Given this list of marker genes ACP5, ARL3, IKBKG, MBTPS2, SMAD4, FGFR2, DHCR7, TBXAS1, NEPRO, OCRL, PLOD2, ACVR1, PMM2, NOTCH3, VPS35L, TBX15 (NCBI Gene Id 6913), B3GLCT, EIF5A, RPL13, PPP1R15B, JAG1, LRP4, PLOD1, CLCN7, ELN, CDH11, UFSP2, FBN1, PPIB, PUF60, CEP104, ADAMTSL2, DVL1, WBP11, CRTAP, LAMA5, KIF22, BGN, RNU4ATAC, GORAB, LTBP3, DPP9, RAD21, AKT1, FANCC, GUSB, SLC39A13, ARSK, IPO8, CFAP410, LIMK1, VANGL2, TMEM218, RAB33B, ALG12, DLL3, ERI1, PTH1R, COL1A1, FANCB, HYLS1, SRP54, CTBP1, ANTXR1, IFT43, TMEM237, UBE3B, ARSB, SOST, COL9A3, HES7, FZD2, ROR2, PYCR1, THPO, TBXT (NCBI Gene Id 6862), RTL1, SH3PXD2B, XYLT1, TENT5A, WASHC5, PDE4D, SERPINF1, CCL2, COL2A1, LYSET, DDR2, KDM6A, FKBP6, RMRP, SUMF1, SKI, DNA2, WNT5A, NSD2, ALPL, ARL13B, P3H1, AEBP1, B3GALT6, KATNIP, MRPS28, TAPT1, RIPPLY2, GTF2I, MMP2, VPS37D, TONSL, KIAA0753, PCYT1A, DNAJC30, METTL27, ZFX, NEU1 (neuraminidase 1), SON, STX1A, ADA (adenosine deaminase), CSF1R, LIFR, HHAT, SOX5, GLB1, DLK1 (NCBI Gene Id 8788), MEG3, MIA3, MBD5, SFRP4, GPX4, GJA1, PIGG, PHLDB1, FOXF1, BUD23, H3-3B, IHH, NOTCH2, FLI1, TBX2, CHRNG, OBSL1, IARS2, DNAJC21, SEC23A, APC, DDRGK1, TRPV4, CANT1, COL9A1, OFD1, CCN2, SPARC, SF3B4, GTF2IRD2, KCNJ8, KYNU, PTCH2, TCTN1, TRIP11 (thyroid hormone receptor interactor 11), CLIP2, MKS1 (NCBI Gene Id 54903), XYLT2, OTUD5, SLC35D1, CUL7, CYP27A1, AHI1, SC5D, USP8 (ubiquitin specific peptidase 8), PEX7, P4HB, TBL2, TBX6, CAPN15, BMP4, EXOC6B, RINT1, FGFR1, CPLANE1, CEP120, GLE1, GTF2IRD1, MESP2, SGMS2, HGSNAT, IFITM5, NMNAT1, ACTB (NCBI Gene Id 60), TOMM7, AIFM1, KDELR2, FIG4, NOTCH2NLC, CHST3, SUFU, WNT1, SLC29A3, MMP13, IFT74, ORC1, COL10A1, BMP1, TCIRG1, COL9A2, EIF2AK3, CCDC8, COL1A2, ARSL, LFNG, POR, NCF1, PIBF1, CDK10, MATN3, NEK1, PLOD3, RSPRY1, POLR3A, CCDC22, PTCH1, MAN2B1, RPS6KA3, MAFB, HSPG2, ALDH1A2, FUZ, MAP3K7, CHD7, CSPP1, TOGARAM1, SEMA3E, SEC24D, SIX6, NAGLU, PIEZO2, SGSH, GNPNAT1, PRKG2, COG1, RFC2, ITCH, TCTN2, TMCO1, ANKRD11, FUCA1, MPL, AIP, SMARCAL1, LTBP1, INPPL1, SLC26A2, GNS, POP1, TWIST1, SERPINH1, TMEM67, BCL11A, TNFRSF11A, CHN1, CEP41, COMP, EIF4H, PDE6D, CBY1 (chibby 1, beta catenin antagonist), CCN6, SOX2, COL11A1, RPS19, INPP5E, SBDS, COG4, PLEKHM1, EXTL3, LRRK1, TBC1D24, TCTN3, IDH1, BAZ1B, VANGL1, DPYSL5, VDR, EBP, NPR2, GNPTAB, FGFRL1, B9D1, MMP14, NELFA, PRKAR1A (NCBI Gene Id 5573), FN1, PAM16, FLNA, NKX3-2, DYM, DVL3, NF1, SALL4, CBS, KMT2D, GALNS, LONP1, AGA, LETM1, ENPP1 (NCBI Gene Id 5167), PTDSS1, PLCB3, GNPAT, FLNB, CSGALNACT1, SF3B2, CPLX1, GLI3, CREB3L1, FGFR3, SMOC1, B9D2, MAX, NANS, LRP5, AXIN1, SLC25A24, ABCC9, HAAO, STAG2, HSPA9, HDAC6, LBR, WNT7A, PAPSS2, TMEM53, IDUA, KIAA0586, ATP6V1B2, DMP1, ZBTB20, ARMC9, PAICS, TRAPPC2, B3GAT3, ATP7A, ACAN, MADD, SLC10A7, TMEM270, RUNX2, MYH3 (NCBI Gene Id 4621), HNRNPR, DHX37, FKBP10, ATRX, COL11A2, here is a description of the gene set: Human Gene Set: HP_ABNORMAL_FORM_OF_THE_VERTEBRAL_BODIES Abnormal morphology of vertebral body. Abnormal form of the vertebral bodies species: Homo sapiens